The following is a description of a gene set: Human Gene Set: HP_ABNORMALITY_OF_CHORIORETINAL_PIGMENTATION studied in species Homo sapiens Abnormality of chorioretinal pigmentation, and this is the list of marker genes: DCT, OAT, MAGEL2, TSC2, TSC1, WT1, SIM1, FAS, PTPN22, SLC25A15, MICOS13, BEST1, PAX6, IFNG, VPS33A